The following is a description of a gene set: MLL-AF4 fusion to transcriptional activation. Pathway ID: N00119. Pathway type: Variant. Pathway class: nt06240 Transcription. Human Gene Set: KEGG_MEDICUS_VARIANT_MLL_AF4_FUSION_TO_TRANSCRIPTIONAL_ACTIVATION Pathway Definition from KEGG: MLL-AF4 == ((CDK9,CCNT)+(MLLT1,MLLT3)+DOT1L) => (LMO2,PBX3,RUNX2,SMAD1,KLF3,MEF2C,HOXA9,HOXA10,JMJD1C,HMGA2,KDM6A,SUPT3H,PROM1,FLT3,BMP2K,IGF1R,CDKN1B,CDK14) species: Homo sapiens, and this is the list of marker genes: FLT3, KDM6A, PROM1, AFF1, DOT1L, HOXA9, KMT2A, SMAD1, HMGA2, PBX3, CDK9, CDKN1B, CCNT2, MLLT1, RUNX2, KLF3, CDK14, MLLT3, HOXA10, SUPT3H, IGF1R, MEF2C, BMP2K, LMO2, CCNT1, JMJD1C